The following is a description of a gene set: species: Homo sapiens Human Gene Set: GSE9601_NFKB_INHIBITOR_VS_PI3K_INHIBITOR_TREATED_HCMV_INF_MONOCYTE_UP from publication Chan G, Bivins-Smith ER, Smith MS, Yurochko AD (PMID 18003728) Genes up-regulated in monocytes after HCMV infection: BAY 11-7082 versus Ly294002. Human cytomegalovirus induces a pro-inflammatory monocyte following infection and we have evidence that NF-κB and phosphatidylinositol 3-kinase are key mediators in this early activation. To begin to address how these signalling pathways are responsible for the rapid activation of infected monocytes, we examined the role these pathways played in the transcriptome of infected monocytes. Global transcriptional profiling using cDNA microarrays revealed a significant number of genes, including inflammatory genes, were regulated in a NF-κB- and/or PI(3)K-dependent manner, identifying these pathways as key cellular control points in the conversion of monocytes to an activated pro-inflammatory state following HCMV infection., and this is the list of marker genes: EPRS1, ZBTB14, CYB5R1, PTPRA, MRPL28, MPI, VDAC1 (NCBI Gene Id 7416), MARCHF6, E2F6, RSPO1, SORT1, MAPK14, IDH1, PARP1, SUPT4H1, CXCR6, TAFAZZIN, BAZ1B, AMZ2, ACAT1, MCEE, CDC23, SOX18, PDK2 (pyruvate dehydrogenase kinase 2), CTC1, TSPAN32, ZMYM1, CCPG1, RHOQ, LCMT1, PDE6D, NME7, AP1S2, MRPL40, CLK3, FAF1, PLEKHA6, CCDC80, ACSS1, HDAC1 (histone deacetylase 1), B3GALNT2 (beta-1,3-N-acetylgalactosaminyltransferase 2), DECR1, GBA2, ADCY7, CNNM3, IRF4, SEC14L1, RDH11, CMBL, TRAM1, SHPRH, IQCC, TRIR, NME3, LTA4H, RALBP1, TMT1A, LRPAP1, ERBB2, ACADVL, USP21, BLOC1S5, DNAJC9, GNPDA1, MLX, SKP2, TRAPPC1, MED20, OSBP, ALDH6A1, POLK, ERMP1, APPL2, YWHAH (tyrosine 3-monooxygenase/tryptophan 5-monooxygenase activation protein eta), RNF181, RDM1, TMEM216, TMX2, SUMO3, METTL8, BTG2, C7orf25, CIAO1, IP6K1, GNPAT, PLCE1, SLC40A1, PNPLA6, TYW1, STK16, FAM50A, HIP1, LSS, CPT1A, SVEP1, TMEM129 (NCBI Gene Id 92305, transmembrane protein 129, E3 ubiquitin ligase), ANKMY2 (NCBI Gene Id 96008), FAM76A, CAV2, IL10RB, GDAP2 (ganglioside induced differentiation associated protein 2), ZMYND8, STARD8, SURF1, SLC46A3, VSIR, GDPD2, HNRNPUL2 (heterogeneous nuclear ribonucleoprotein U like 2), MAVS, KLRD1, TM6SF1, ILKAP, PURG, SMO, CBY1, MGME1, NDUFA9, TFCP2, ME2, LAIR1, PPARG, SYNE1, HAUS8, CXCR3 (NCBI Gene Id 2833), RGS10, RBL2, PRKRA, IDE, ZMAT3, ACTR8, KMT5C, HIKESHI, RFC2, TFEB, FCER1A, CRISPLD1, TRAPPC2B, IFT46, PPM1B, ARL16, C5orf22, WRAP73, UFSP2, PAK1, CDKN2AIPNL, SQOR, STBD1, REM1, VPS26B, RNF130, PCMTD2, AP2M1, PTGS1, NCBP2, ADNP, SGMS1, PIGC, OMA1, ACP2, SNX14, TMEM98, DNASE1L1, MRPL18, CPT2, PITPNC1, TLX1, ACAA2, CCDC22, TCIM, CAVIN2 (caveolae associated protein 2), ASH2L, PRKAG1, PTGR3 (prostaglandin reductase 3), ENSA, THYN1, GMPR2, DCAF4, PIP4P2, KLF10, C11orf54, CENPO, OSBPL2 (NCBI Gene Id 9885), FH, CD300A, TMEM35A, GOLM1, GLRB, SPN, IRS1, CDK16, BCS1L, TCTN3, WIPI2, PIK3R2, ALG14, CYP2S1, FOXK2, ANKRD46, COMT, RARG